Given this list of marker genes Ddx5, Elavl4, U2af1l4, Rbpms, Rbm4, Ptbp1, Hnrnpu, U2af2, Prpf8, Snrpc, Celf1, Slu7, Celf4, Zc3h14 (zinc finger CCCH type containing 14), U2af1, Slbp, Rnpc3, Hnrnpa2b1, Zrsr2, Rbm20, Srsf2, Hnrnpl, Srsf6, Rbm24, Rbm41, Hnrnpa1 (heterogeneous nuclear ribonucleoprotein A1), Arglu1, Prpf39, Ep300, Per2, Tra2b (transformer 2 beta), Rbm7, Rbm22, Celf2, Tardbp, Hnrnpk, Lsm1, Sox9, Eri1, Tex16, here is a description of the gene set: Mouse Gene Set: GOMF_PRE_MRNA_BINDING species: Mus musculus Binding to a pre-messenger RNA (pre-mRNA), an intermediate molecule between DNA and protein that may contain introns and, at least in part, encodes one or more proteins. Introns are removed from pre-mRNA to form a mRNA molecule.